The following is a description of a gene set: species: Homo sapiens Human Gene Set: GOBP_REGULATION_OF_SPONTANEOUS_SYNAPTIC_TRANSMISSION Any process that modulates the frequency, rate or extent of spontaneous synaptic transmission., and this is the list of marker genes: PRKN, AGER, APP, SLC12A2, STX1B, ITGB1